Given this list of marker genes RP1, OPN1SW, GUCY2D, NMT1, PDE6B, GNA11, GNAQ, RRH, GRK7, OPN1LW, OPN1MW2, ABCA4, GPR88, OPN3, OPN1MW, RHO, OPN5 (NCBI Gene Id 221391), CAMKMT, GRK1, PNPLA2, ELOVL4, OPN4, GUCY2F (guanylate cyclase 2F, retinal), PCP2, GRK4, RBP4, GNAT1, GPR52, RGR, NMT2, TTR, AIPL1, SAG, GRM6, OPN1MW3, PDE6C, GNAT2, GNAT3, here is a description of the gene set: The series of events in which a visible light stimulus is received by a cell and converted into a molecular signal. A visible light stimulus is electromagnetic radiation that can be perceived visually by an organism; for organisms lacking a visual system, this can be defined as light with a wavelength within the range 380 to 780 nm. Human Gene Set: GOBP_DETECTION_OF_VISIBLE_LIGHT species: Homo sapiens